Given this list of marker genes Ntrk2, A2m, Pzp, Fstl4, Hap1, here is a description of the gene set: species: Mus musculus Mouse Gene Set: GOMF_BRAIN_DERIVED_NEUROTROPHIC_FACTOR_BINDING Binding to brain-derived neurotrophic factor.